The following is a description of a gene set: species: Homo sapiens Frontal hirsutism Human Gene Set: HP_FRONTAL_HIRSUTISM Excessive amount of hair growth on forehead., and this is the list of marker genes: FLNA, PRMT7, EP300, CKAP2L, SLC25A12, CREBBP, MEG3, RTL1, TASP1, DLK1